The following is a description of a gene set: Genes down-regulated in breast cancer samples positive for ESR1 compared to the ESR1 negative tumors. Human Gene Set: DOANE_BREAST_CANCER_ESR1_DN Little is known of the underlying biology of estrogen receptor-negative, progesterone receptor-negative (ER(-)/PR(-)) breast cancer (BC), and few targeted therapies are available. Clinical heterogeneity of ER(-)/PR(-) tumors suggests that molecular subsets exist. We performed genome-wide expression analysis of 99 primary BC samples and eight BC cell lines in an effort to reveal distinct subsets, provide insight into their biology and potentially identify new therapeutic targets. We identified a subset of ER(-)/PR(-) tumors with paradoxical expression of genes known to be either direct targets of ER, responsive to estrogen, or typically expressed in ER(+) BC. Differentially expressed genes included SPDEF, FOXA1, XBP1, CYB5, TFF3, NAT1, APOD, ALCAM and AR (P<0.001). A classification model based on the expression signature of this tumor class identified molecularly similar BCs in an independent human BC data set and among BC cell lines (MDA-MB-453). This cell line demonstrated a proliferative response to androgen in an androgen receptor-dependent and ER-independent manner. In addition, the androgen-induced transcriptional program of MDA-MB-453 significantly overlapped the molecular signature of the unique ER(-)/PR(-) subclass of human tumors. This subset of BCs, characterized by a hormonally regulated transcriptional program and response to androgen, suggests the potential for therapeutic strategies targeting the androgen signaling pathway. studied in species Homo sapiens from publication Doane AS, Danso M, Lal P, Donaton M, Zhang L, Hudis C, Gerald WL (PMID 16491124), and this is the list of marker genes: S100A8, BCL11A, ART3, SOX11, UPP1, ASS1, ROPN1 (rhophilin associated tail protein 1), BBOX1, MMP7, CXCL8, GABBR2, PLAAT1, MSLN, GAL, PALS2, ZIC1, UGT8, SFRP1, KRT6B (keratin 6B), DSC2, RARRES1, KRT5, GJB3, GABRP, COL9A3, TTYH1, PSAT1, CRYAB, PGBD5, SCRG1, ELF5, EGFR, EN1, CHST3, PAX6 (NCBI Gene Id 5080), BMAL2 (basic helix-loop-helix ARNT like 2), MIA, TTLL4, FABP7, SLPI, MID1, IGF2BP3, SOD2, LY6D, VGLL1, FOXC1, KRT16